The following is a description of a gene set: Full cheeks Increased prominence or roundness of soft tissues between zygomata and mandible. Human Gene Set: HP_FULL_CHEEKS species: Homo sapiens, and this is the list of marker genes: PIGN, ACTG1, IFT122, WDR26, PUF60, DDB1, RNU4-2, SC5D, PAX1, LARS1, EDN1, GATA4, TCF4, AIP, HEATR3, GPR101, STX16, KDM6B, PCNT, CCDC88A, FLNA, LIFR, WNT3, RPGRIP1, SETD1B, SH3BP2, PIK3CA, GNAS, CLCN3, VPS33A, AGL, ACTB, KMT2E, FBXO11, DPM1, TBL1XR1, B9D1, MEG3, CRLF1, TMEM231, KRAS, MLXIPL, MAP2K1, LMNA, SLC35A2, ELMO2, LMX1B, SLC26A2, KMT2B, IDS, H1-4, MKS1, RSPO2, IARS1, SH3PXD2B, NOTCH2, HRAS, EIF2S3, ZNHIT3, FAT4, PLCB4, MYT1L, KIDINS220, EEF1A2, WAC, CLCF1, PURA, TCTN1, ELN, YARS1, RPGRIP1L, HSPG2, SOX11, ATP7A, DTYMK, IER3IP1, INTS1, DLK1, STXBP1, DPYD, ZPR1, B9D2, PIGQ, MAPK8IP3, PIGB, SPTBN1, GNAI3, TMEM107, GNB2, CC2D2A, TMEM67, TBX4, MOCS1, TXNDC15, TAFAZZIN, LTBP3, RTL1, IFT52, BMP2, PCLO, SLC29A3, BRAF, NRAS, IFT140, HDAC9, CSPP1, OCRL, FBN1, DDX3X, EP300, TBCE, WDR35, SNX14, IDUA, KIF11, CPE (carboxypeptidase E), EYA1, SON, TMEM237, TCTN2, CEP290, MOCS2, BICRA, PPP1R15B, NALCN, SIM1, MAP3K7, ESAM, MTHFS, EXTL3, TCTN3, FGF3, TECPR2, STAG2, GNPTAB, ASXL1, TRMT10A, SETD1A, CDK5, UFC1, WDR19, TGDS, NEK9, SLC37A4, PSPH, BCKDK (branched chain keto acid dehydrogenase kinase), TMEM216, TFE3, CREBBP (CREB binding protein), KCNH1, CDC42BPB, MAP2K2, AFF4, SHANK3 (SH3 and multiple ankyrin repeat domains 3), KLHL7